Given this list of marker genes Slc2a1 (NCBI Gene Id 20525), here is a description of the gene set: studied in species Mus musculus part of: Metabolism of water-soluble vitamins and cofactors Reactome Pathway: Vitamin C (ascorbate) metabolism This event has been computationally inferred from an event that has been demonstrated in another species.<p>The inference is based on the homology mapping from PANTHER. Briefly, reactions for which all involved PhysicalEntities (in input, output and catalyst) have a mapped orthologue/paralogue (for complexes at least 75% of components must have a mapping) are inferred to the other species. electronically inferred by orthology from the curated human pathway